Given this list of marker genes MMP12, DPPA2, GIMAP1, IFIT1, GUCD1, OSTF1 (NCBI Gene Id 26578), KCNC2, KCNE5, CXXC5, TSPO, ZNF536, SHISA5, SLC27A5, SLC66A3, RAB3IP, SLFN5, C3orf80 (chromosome 3 open reading frame 80), CALCOCO2, RBMXL2, IRGM, AMIGO2, AVEN, TMIE, RNF135, TNFRSF25, LINC01973, SMC4, TNFAIP8L1, HERC6 (HECT and RLD domain containing E3 ubiquitin protein ligase family member 6), LFNG, ACSBG1, OR5D18, MB, EMC9, FAM78A, CCDC120, CD200R1L, CARTPT, IGFLR1, ADGRE5, IL17RA, PHF20L1, AXDND1, ST8SIA6, CEP97, LDLRAP1, CRLF3, CCDC90B, SMURF2, H1-4, NCAM2, FCAMR (Fc alpha and mu receptor), PXYLP1, PYCARD, SGK1, RIMS4, IFI44, RAPGEF4, KIAA0586, ALAS1, SMPDL3A, TAS2R1, IL13, ADD3, CLCA2, HOXD4, SIDT1, BAZ1B, HAS3, APPL2, DNAH8, MS4A6A, SLC35F5, SQOR (sulfide quinone oxidoreductase), NCMAP, ESYT1, EMP3, PHYHD1, CASTOR1, NXPE3, MGAT4C, TMPRSS13, QPRT (quinolinate phosphoribosyltransferase), PELI1, DTX1, YPEL3, COL9A3, ACSS2, PDE4B, TMEM71, VRK3, ENTREP3, NAT2, C5 (NCBI Gene Id 727), PPP2R5A, TXNIP (thioredoxin interacting protein), KLHDC2, RAB21, PSTPIP2, SLC25A12, ALS2CL, B4GALT5, RP1L1, PGP, FBXL13, RRM2B, PTX3, ADH1C, CERS6, SELPLG, PCED1B, CD164L2, TRIM34, GUCY1A1, F2RL1, SGSH, PTS, PLEKHA2, CRP, NDRG3, PIEZO1 (NCBI Gene Id 9780), C5orf47, ACOX3, CDIPT, MRO, ACAP1, DGKA, FAM229B, OAS1, CTPS2, ABTB3, FBXO42 (NCBI Gene Id 54455), ICA1L (NCBI Gene Id 65068), NFATC3, ITGB7, EHBP1L1, E2F7, IRF7, IGFBP4, GM2A, FLT3LG, ITPR2, PTCHD3, ZBTB16, RASA3, NYAP1, ANKRD26 (NCBI Gene Id 22852), KLF3, WSCD2, RHCG, DAXX, OAS2, LMNTD2, ABCD1, TNS4, ARSB, PIGR, SYNPR, IQGAP1, PDE3B, S1PR4, MAN1C1, CRMP1, TMEM236, SCN5A, TSPAN9, DMRT2, KLHDC1, TBC1D1, KLF2, GJA3, TLR1, DNAJA4, HVCN1, TRAF5, GRAMD4, C3orf52, RFLNB, CTSW, ANK3, PTGER2, CMAS, IFT80, FAM234A, USP18, GABRR2, SYNE2, RNF213, S1PR1, IL6R, TMEM175, ZBTB44, ELOVL7, RASGRP2, HPD, IFIH1, C1QTNF2, DUSP23, TKTL1, SHLD2, here is a description of the gene set: After positive selection in the thymus, the newly generated single positive (SP) thymocytes are phenotypically and functionally immature and undergo apoptosis upon antigen stimulation. In the thymic medullary microenvironment, SP cells progressively acquire immunocompetence. Negative selection to remove autoreactive T cells also occur at this stage. We have defined four subsets of CD4 SP, namely, SP1, SP2, SP3, and SP4 that follow a functional maturation program and a sequential emergence during mouse ontogeny.We used microarray to detail the global programm of gene expression during the maturation of murine CD4 single positive thymocytes Genes down-regulated in comparison of SP1 thymocytes versus SP3 thymocytes. studied in species Homo sapiens from publication Teng F, Zhou Y, Jin R, Chen Y, Pei X, Liu Y, Dong J, Wang W, Pang X, Qian X, Chen WF, Zhang Y, Ge Q (PMID 22022412) Human Gene Set: GSE30083_SP1_VS_SP3_THYMOCYTE_DN